The following is a description of a gene set: species: Homo sapiens Genes having at least one occurrence of the motif TBTGCACHCGGCCC in the regions spanning 4 kb centered on their transcription starting sites. This matches the MTF1 transcription factor binding site V$MTF1_Q4 (v7.4 TRANSFAC). Human Gene Set: MTF1_Q4, and this is the list of marker genes: NFAT5, SLC6A14, JADE2, RAPGEFL1, TMEM229B, FLT4 (fms related receptor tyrosine kinase 4), HCN4, ANAPC1, LAMTOR1, PAQR4, KCNJ10, AQP4, ANP32A, LHX4, MTF2, MT2A, CNGB1, PPP2R5D, H2AZ2, INTS13, GPM6B, ATF2, PPP2R2B, DAB2IP, LIG1, SPACA6, ELK3, CYP26A1, SLC9A7, PHLPP1, RASAL2, EEF2K, PURA, GLI1, POLK, AQP4-AS1, NRF1, LCK, TMEM105, RGS6, EIF5A, SPARCL1, CABP7, POLR2H, EGR1, SLITRK2, PAQR6, VSNL1, SYT12, CNNM2, SEMA3A, XPO7, MRC2, NXPH3, CNPY3, C6orf136, DCAF1, HDAC7, HDAC3, SAMTOR, PPP4R4, TMEM50B, EP300, FAM120C, ZSWIM8, FAM219A, RPAP1, GABRA4, MYLK, MARCKS, CAVIN1, PRKAG1, PIP4K2A, CLCN2, MNT, SRSF8, LHX6, TNMD, PTGES3, TNKS2, GPC6 (NCBI Gene Id 10082), DNM1, HTR7, PDZD4 (PDZ domain containing 4), COL12A1, SOBP, MT4, KLF15, VEGFA, CDAN1 (codanin 1), DLL1, CERT1, NDUFA11, CEP41, DUSP7, FAM222B, KCNN2, U2AF2, PPP1R16A, TMEM187, HMBOX1 (NCBI Gene Id 79618), OLFM2, ZCWPW1, MLLT6, C4orf33, TIAL1, YPEL5, KANSL1L, PCDH10, CLASRP, PPME1, CTNND1, PAX8, NPPC, GDPD3, WDR53, C2CD2L, DGKG, CCNJL, JUP, EIF4G2, EHD2, FMNL1, MT1E, SCLT1, PCDH1, KIF3A, CNTFR, CDK6, ADAMTS9, NNAT, ADAMTSL2, DNAI1, ACTN4, WDTC1, JUN, ZNF362, CNNM1, NDUFAB1, P3H4, RPS6KA3, BCL9, ARVCF, CADPS, ADGRL1, FEZF2, RELL2, CDC25A, DLG2, TOB1, XPO5, RHOT1, DTX1, PTCHD4, FOXA2, MECP2, ZSWIM9, FOXO4, REPIN1, HOXC6, DOCK11, POLH, SPATA32, CNBP, THAP7, STAC2, RNF19B, PPM1J, NFIL3, SLC30A2, PICALM, BZW2, SAP130, CLIP3, FGFR1OP2, PLEC, VWCE, GAREM1, CACNA1F, CREB1, RBBP7, CDIN1, ARTN, PHKA1, ABTB2, SALL1, ZNF385A, HR, THAP7-AS1, HMG20B, CHRD, ZFP91, HMGA1, FGF14, MLLT10, MGLL, ZBTB7A, CBLN1, HELZ2, HES7, BEX1, PPP3CA, PTPRG, IFFO1, ZNF48, MTSS1, RAP1GDS1, TNXB, SCRT2, HOXC4, CRTAC1, CIZ1, INTS9, CADM1, POU2F1, CALCR, MECOM, KHSRP, GPC4, PDE7A, CELF4, CCDC177, MYH13, GRIN3A, RIN1, SMARCA2, CHPF, ANKMY2, ARMCX3, GNAI2, MRPL45, SENP1, TMTC2, MEPCE, SFRP1, NUAK1, EMILIN3, MTMR4, MAGED2, FST, CHRM1, RELA, SEMA6C, NKX2-1, PORCN, CDCP1, H1-0, GSC, UBAC1, EFNA5, KCTD12 (NCBI Gene Id 80710), PCDH7, JPH3, FBXL20, ST8SIA2, WAS